Given this list of marker genes MOGS (NCBI Gene Id 7841), MGAT1, GANAB, CANX, PRKCSH, here is a description of the gene set: studied in species Homo sapiens Human Gene Set: REACTOME_MATURATION_OF_SARS_COV_1_SPIKE_PROTEIN Maturation of spike protein